Given this list of marker genes GABRA3, KCNJ18, RYR2, DSP, SCN4A, LIMS2, DES, PLN, JUP, SGCD, ABCC9, TRDN, ALPK3, CACNA1S, JPH2, TKFC, KCNE3, MYPN, SCN5A, TPM2, CSRP3, CASQ2, TPM3, here is a description of the gene set: Reduced systolic function Human Gene Set: HP_REDUCED_SYSTOLIC_FUNCTION studied in species Homo sapiens